Given this list of marker genes Gadl1, Mpst, Ethe1, Slc25a10, Tst, Ado, Fmo1, Suox, here is a description of the gene set: This event has been computationally inferred from an event that has been demonstrated in another species.<p>The inference is based on the homology mapping from PANTHER. Briefly, reactions for which all involved PhysicalEntities (in input, output and catalyst) have a mapped orthologue/paralogue (for complexes at least 75% of components must have a mapping) are inferred to the other species. studied in species Mus musculus electronically inferred by orthology from the curated human pathway Reactome Pathway: Degradation of cysteine and homocysteine part of: Sulfur amino acid metabolism